The following is a description of a gene set: Mouse Gene Set: GOBP_CELL_JUNCTION_DISASSEMBLY The disaggregation of a cell junction into its constituent components. studied in species Mus musculus, and this is the list of marker genes: Vangl2, Kcnk13, Map4k4, Prickle1, C1qb, C3, Epha4, Dusp3, C1ql1, Iqsec1, Snai2, Mylk3, Tgfb3, Cd47 (NCBI Gene Id 78539), Adgrb3, Plxnc1, Mapre2, Cx3cr1, Cdk5, Arf6, Abcc8, Pik3r1, C1qc, Fer, Il1b, Asb17, Ngef, Tgfbr1, Itgam, Trem2, Ston1, Sarm1, C1qa, Itgb1